The following is a description of a gene set: An abnormality of the base of the skull, which forms the floor of the cranial cavity and separates the brain from other facial structures. The skull base is made up of five bones: the ethmoid, sphenoid, occipital, paired frontal, and paired parietal bones, and is subdivided into 3 regions: the anterior, middle, and posterior cranial fossae. The petro-occipital fissure subdivides the middle cranial fossa into 1 central component and 2 lateral components. Human Gene Set: HP_ABNORMAL_SKULL_BASE_MORPHOLOGY studied in species Homo sapiens Abnormal skull base morphology, and this is the list of marker genes: ZIC1, POMK, COG1, CDKN1C, SETBP1, TUBA1A, IGF2, PUF60, PHGDH, DPH2, POMGNT1, RTL1, CDH2, RAPSN, FTO, EVC2, B3GALT6, MAN2B1, CPT2, TMEM67, CSPP1, PGAP2, RNU4-2, BUB1, MAB21L1, ALDH7A1, VPS35L, PI4K2A, RNU12, FLNB, B4GALT1, CREBBP, SLC4A2, NUP88, NOTCH3, POGZ, FOXC1, ZFX, ATP6V1B2, TAF8, COG8, VPS51 (VPS51 subunit of GARP complex), POMT1, DPH1, CRPPA, CNOT3, OPHN1, CLP1 (cleavage factor polyribonucleotide kinase subunit 1), TIMMDC1, SOX4, TMEM237, PPP1CB, BCOR, SMARCA4, CPLANE1, TMEM107, ABCC9, USP9X, SUFU, PMM2, BUB3, ASXL1, POMT2, DOK7, MSX2, SEMA3E, LBR, AHDC1, SIX2, B3GALNT2, VRK1, WDR35, KATNB1, BRF1, RPGRIP1L, MTM1, DYRK1A, VSX1, POLR1A, MYF5, LARGE1 (NCBI Gene Id 9215), RAB18, SMG9, BUB1B, TBX15, RXYLT1 (ribitol xylosyltransferase 1), PITX1, NOTCH2, DYNC2H1, B9D2, MKS1, SMARCC2, ARID1B, TMEM216 (NCBI Gene Id 51259), TGFB1, TUBB, ZEB2, COL1A2, MID1, FAR1, KCNQ1OT1, ACP5, ERCC5, EIF4A2, CEP57, GJB6, TMEM53, DENND5A, SLC5A6, CSF1R, EP300, DHCR7, ATP6V1A, TXNDC15, GDF6, NRAS, GLI3, CTU2, FGFR2, B9D1 (B9 domain containing 1), APC2, DKK1, CC2D2A, GPC4, SIK3, PTH1R, DLK1, TCTN1 (tectonic family member 1), EBP, NSD1, ARMC9, BANF1, SMARCB1, KIF5A, FLVCR2, IFT80, HYLS1, SLC31A1, KIF7, FGF3, WDR81 (WD repeat domain 81), AP1S2, PMPCA, TMEM231, FBXL4, FKTN, GPC3, TCTN2, GNAS, SNORD118, PDGFRB, ATP6V0A2, AFF3, SLF2 (NCBI Gene Id 55719), ABAT, PIGU, POMGNT2, HRAS, POLR2A, CHD7, TMEM138, DPF2, TNFRSF11A (TNF receptor superfamily member 11a), PIGN, ALX4, OFD1 (OFD1 centriole and centriolar satellite protein), DPYSL5, CDC42, PPFIBP1, TUBB2A, MAPKAPK5, PLG, SMARCD1, DYNC2I1, NPHP3, NDUFC2, WDR73, MEG3, ZBTB20, MAP3K7, KIF21A, CEP120 (centrosomal protein 120), ALG3, FKRP, ZSWIM6, MUSK, RFT1, IL6ST, EVC, MYOD1, WASHC5, GTPBP2, BLTP1, POLR3A, CAMSAP1, DDX3X, RNF113A, FLNA, MRE11, SH3PXD2B, EDEM3, CEP290, SMARCE1, PACS2, RPGRIP1, PTDSS1, TCTN3 (NCBI Gene Id 26123), SLC18A3, ATP6V1E1, ALDH18A1, NFU1, SOX3 (NCBI Gene Id 8256), SLC35A2, EBF3, MAGEL2, MBD5, KRAS, CCDC22, PRX, TRIP13, FBXO28 (F-box protein 28), DPH5, NEK8, SRPK3, COL4A1, TBC1D24, KCNQ1, ARID2, ESCO2, ANKH, SOX11, DAG1, COL1A1, PIEZO2, RAC1, TBCK, AMER1, C2CD3, EXOSC8, KIAA0586, ARID1A, GJB2, PLCH1, PLPBP (pyridoxal phosphate binding protein), B4GAT1, ACADVL, SH2B1, DYNC2I2, FGFR1 (NCBI Gene Id 84151)